Given this list of marker genes SUCLG1, SLC25A3, MYH14, FH, TMEM126B, MFF, FDXR, LYRM4, CHKB, GGPS1, here is a description of the gene set: Human Gene Set: HP_ABNORMAL_MITOCHONDRIAL_SHAPE species: Homo sapiens Abnormal mitochondrial shape An anomaly in the surface contour of mitochondria.